Given this list of marker genes PM20D1, SLC25A27, UCP1, SLC25A4, SLC25A14, UCP3, UCP2, here is a description of the gene set: part of: Aerobic respiration and respiratory electron transport Reactome Pathway: Mitochondrial Uncoupling studied in species Homo sapiens The protonmotive force across the inner mitochondrial membrane built up by respiratory electron transport does not go entirely into ATP production. Transport proteins of the SLC25 type utilize the gradient to symport small molecules with protons into the matrix, simultaneously generating heat ("thermogenesis"). UCP1 and AAC1 have been shown to import protons exclusively and are responsible for most heat generated in brown fat and other tissue, respectively.<br><br>Uncoupling proteins (UCPs) are members of the mitochondrial transport carrier family. The crystal structure of one member of the family, the adenine nucleotide translocase, is known, and UCPs can be successfully folded into this structure to indicate their probable 3D arrangement.<br><br>The most studied member of the family, UCP1, catalyzes adaptive thermogenesis (i.e., heat generation) in mammalian brown adipose tissue. It does so by promoting a leak of protons through the mitochondrial inner membrane, which uncouples ATP production from substrate oxidation, leading to fast oxygen consumption and ultimately to heat production. The thermogenic activity of UCP1 in brown adipose tissue plays an important role when the organism needs extra heat, e.g., during cold weather conditions (for small rodents), the cold stress of birth, or arousal from hibernation. UCP1 homologs have been found in lower vertebrates such as fish, where their role is unclear (Cannon & Nedergaard 2004, Jastroch et al. 2005).<br><br>The proton conductance of UCP1 in brown adipose tissue is tightly controlled. It is strongly inhibited by physiological concentrations of purine nucleotides. This inhibition is overcome by fatty acids released from intracellular triacylglycerol stores following adrenergic activation in response to cold or overfeeding. Other activators include superoxide, retinoic acid, the retinoid 4-benzoic acid (TTNPB) and reactive alkenals, such as hydroxynonenal. <br><br>There is strong evidence that the regulated uncoupling caused by these proteins attenuates mitochondrial reactive oxygen species production, protects against cellular damage, and (in beta-cells) diminishes insulin secretion. There are also untested suggestions that their transport of fatty acids may be physiologically important (Brand & Esteves 2005, Esteves & Brand 2005, Krauss et al. 2005). <br><br> Several models have been proposed for the molecular mechanism by which fatty acids lead to increased proton conductance by UCP1 in brown adipose tissue mitochondria and presumably by the other UCPs. We have depicted the most likely model, the "fatty acid cycling" model, in this pathway.<br><br>Studies of mouse models and cultured human cells have suggested that oleoyl-phenylalanine, synthesized by extracellular PM20D1, may play a role in uncoupling independent of the action of UCPs. Its synthesis and hydrolysis are annotated here.